The following is a description of a gene set: Genes down-regulated in the brain cortex of mice that were exposed to an enriched learning environment for one day. from publication Rampon C, Jiang CH, Dong H, Tang YP, Lockhart DJ, Schultz PG, Tsien JZ, Hu Y (PMID 11070096) Mouse Gene Set: RAMPON_ENRICHED_LEARNING_ENVIRONMENT_EARLY_DN An enriched environment is known to promote structural changes in the brain and to enhance learning and memory performance in rodents. To better understand the molecular mechanisms underlying these experience-dependent cognitive changes, we have used high-density oligonucleotide microarrays to analyze gene expression in the brain. Expression of a large number of genes changes in response to enrichment training, many of which can be linked to neuronal structure, synaptic plasticity, and transmission. A number of these genes may play important roles in modulating learning and memory capacity. species: Mus musculus, and this is the list of marker genes: Pafah1b1, Nrgn, Sptbn1, Mcpt4, Prep, Cit, Casp6, Rxra, Mt3, Bax, Dnajb6